The following is a description of a gene set: Human Gene Set: GOMF_FATZ_BINDING species: Homo sapiens Binding to a member of the FATZ family of proteins, filamin-, actinin-, and telethonin-binding proteins of the Z-disc of striated muscle. FATZ proteins are located in the Z-disc of the sarcomere and are involved in a complex network of interactions with other Z-band components., and this is the list of marker genes: ACTN2, MYOZ2, TCAP, MYOZ3, MYOZ1 (NCBI Gene Id 58529)